The following is a description of a gene set: Human Gene Set: REACTOME_DDX58_IFIH1_MEDIATED_INDUCTION_OF_INTERFERON_ALPHA_BETA DDX58/IFIH1-mediated induction of interferon-alpha/beta species: Homo sapiens, and this is the list of marker genes: HMGB1, IFNA14, SAA1, MAP3K1, ATG12, IFNA10, IFNA6, ITCH, TRAF6, FADD, SIKE1, CASP10, ISG15, UBE2D3, UBB, UBC, CHUK, IFNA8, CREBBP, PIN1, IFIH1, UBE2L6, HSP90AB1, TRAF2, IFNA4, S100B (NCBI Gene Id 6285), IFNA21 (interferon alpha 21), TKFC, NFKBIA, UBE2K, RELA, IKBKG, IRF7, TRIM25, NFKB1, IRF3, IFNA1 (NCBI Gene Id 89955), HERC5, UBE2D2, IFNB1, S100A12, IFNA5, CASP8, UBE2D1, TANK, ATG5, IKBKE, TRIM4, RNF125, UBA52, TOMM70, NKIRAS2, OTUD5, NLRC5, DHX58, TBK1, AGER, EP300, NFKBIB, RNF216, HSP90AA1, RPS27A, IFNA7, NFKB2, UBA7, IFNA2, RIPK1, TAX1BP1, PCBP2, NLRX1, RIGI, NKIRAS1, APP, TNFAIP3, IFNA17, CYLD, IFNA13, MAVS, RNF135, TRAF3, IKBKB, IFNA16